The following is a description of a gene set: Any process that activates or increases the frequency, rate or extent of nuclear-transcribed mRNA catabolic process, deadenylation-dependent decay. Mouse Gene Set: GOBP_POSITIVE_REGULATION_OF_NUCLEAR_TRANSCRIBED_MRNA_CATABOLIC_PROCESS_DEADENYLATION_DEPENDENT_DECAY studied in species Mus musculus, and this is the list of marker genes: Cpeb3, Dhx36, Zfp36l2, Cnot7, Zfp36l1, Pabpc1, Tnrc6b, Cnot1, Tob1, Tnrc6c, Ago2, Tnrc6a, Zfp36